The following is a description of a gene set: The gene expression program underlying the specification of human cell types is of fundamental interest. The study authors generated human cell atlases of gene expression and chromatin accessibility in fetal tissues. For gene expression, the study authors applied three-level combinatorial indexing to >110 samples representing 15 organs, ultimately profiling ~4 million single cells. The study authors leveraged the literature and other atlases to identify and annotate hundreds of cell types and subtypes, both within and across tissues. Our analyses focused on organ-specific specializations of broadly distributed cell types (such as blood, endothelial, and epithelial), sites of fetal erythropoiesis (which notably included the adrenal gland), and integration with mouse developmental atlases (such as conserved specification of blood cells). These data represent a rich resource for the exploration of in vivo human gene expression in diverse tissues and cell types. Human Gene Set: DESCARTES_FETAL_STOMACH_MUC13_DMBT1_POSITIVE_CELLS from publication Cao J, O'Day DR, Pliner HA, Kingsley PD, Deng M, Daza RM, Zager MA, Aldinger KA, Blecher-Gonen R, Zhang F, Spielmann M, Palis J, Doherty D, Steemers FJ, Glass IA, Trapnell C, Shendure J (PMID 33184181) Marker genes curated from the annotated cluster as represented in the Descartes Human Gene Expression During Development database. studied in species Homo sapiens, and this is the list of marker genes: MT1G, SLC26A3, RBP2, LINC00543, PDZD7, DMBT1, GPD1, MIR194-2HG, APOB, VIPR1, CREB3L3, GDPD2, IYD, ADGRG7 (NCBI Gene Id 84873), MEP1A, NR1I2 (nuclear receptor subfamily 1 group I member 2), OTC, LRRC66, EPS15-AS1 (NCBI Gene Id 105378720), MT1H, GPA33, CDHR2, SPIB, CES2, ACE2, CDH17, MUC17, CYP2B7P, PRSS3, SLC5A9, CLDN2, EPS8L3, OLFM4, MUC13, MOGAT2, MT2A, MTTP, LGALS4, MYO7B, PIGR, ENPP7, KRT20, ANKS4B, ISX (NCBI Gene Id 91464), BAIAP2L2, ADRA2A, MALRD1, CDHR5 (NCBI Gene Id 55618), NMUR2, TM4SF20, MGAM2, GUCA2B, GDA, SLC15A1, TRPM6, MAMDC4, MELTF, PLA2G12B, TRIM31, PCK1, AMN, NR1H4, APOA4, ONECUT2, SULT1E1, SCTR, GUCY2C, SLC6A20, CPS1, CCL25, CDX1, GK, FZD5, HSD17B2, PHGR1, HNF4A-AS1, GCNT3, SLC17A4, ANKRD40CL, APOC3, ALDOB, ACSL5, SLC19A3, MGC32805, CHP2, APOA1 (apolipoprotein A1), MT1F, MUC3A, CHST13 (NCBI Gene Id 166012), KHK, BTNL3, SI, SLC5A12, ABCC6P1, ANXA13, HKDC1